The following is a description of a gene set: species: Homo sapiens Any process that increases the rate, frequency or extent of neuron projection development. Neuron projection development is the process whose specific outcome is the progression of a neuron projection over time, from its formation to the mature structure. A neuron projection is any process extending from a neural cell, such as axons or dendrites (collectively called neurites). Human Gene Set: GOBP_POSITIVE_REGULATION_OF_NEURON_PROJECTION_DEVELOPMENT, and this is the list of marker genes: PLK5, SERPINF1, MARK2, TMEM106B, TUBB2B, TMEM30A, PTPRD, KAT2B, RGS2, NCKIPSD, BCL11A, ITPKA, EPO, EEF2K, BMP7, CAMK2B (calcium/calmodulin dependent protein kinase II beta), CBFA2T2 (NCBI Gene Id 9139), DVL1, ARMCX5-GPRASP2, FYN, ITGA3, DPYSL3, TWF1, MIR222, APBB1, DISC1, MIR221 (NCBI Gene Id 407006), PAFAH1B1, KHDC3L, RAP1A, LRP8, PACSIN1, ANKRD1, P3H1, ABL2, MIR431 (microRNA 431), AVIL, SF3A2, LTK, MIR133B, SLC30A1, RETREG3, ATP8A2, AP2A1, FEZ1, EHD1, COBL, GPRASP3, PTK2B, TOX, ROBO3, DDR1, NTRK2, NDNF, ZDHHC15, CFLAR, WASHC5, TRIM67, ALKAL2, ZNF804A, IL1RAPL1, CX3CL1, ALKAL1, FES, ARHGAP35, FBXO38, CUX2, NTRK3 (neurotrophic receptor tyrosine kinase 3), PTN, BMPR1A, EPHB2, ARSB, RAPGEF2, S100A9, STYXL1, DAB2IP, CAMK1, NTRK1, ALK, BMP5, DBN1, NEGR1, LRRC7, TWF2, FZD1, PLXNB3 (NCBI Gene Id 5365), RAPGEF1, CAPRIN2, STAU2, ENC1, RIT2, FGFR1, LYN, PRKD1, CAMK1D, GPC2, PPP2R5B, SETX, RELN, MAGI2, PLPPR5, SCARB2, ABL1, DMD, VLDLR, AMIGO1, ADNP (activity dependent neuroprotector homeobox), PLA2G3, ATP1B2, PRKCI, PTK7, KDM1A, CNTF (ciliary neurotrophic factor), DDR2, DDX56, BRAF, SMAD1, ANKRD27, NCK1 (NCK adaptor protein 1), SHOC2 (NCBI Gene Id 8036), ATF1, ARF6, PTK6, NPTN, EZH2, ATOH7, BDNF, SCN1B, KATNB1, FIG4, RET, WNT5A, BAIAP2, STMN2, FUT9, EP300, MIR200C, NGF, RGMA, MDK, APOE, TENM3 (NCBI Gene Id 55996), PLXNB2, CNTN1, KIDINS220, NFE2L2, SNX3, RYK, SERPINI1, ITGA6, INS, TNN, NDRG4, PUM2, CAPRIN1, EPHA3, DHX36, GRN, SCARF1